Given this list of marker genes EHD1, MYOG (NCBI Gene Id 4656), MIR515-1, ADGRB1, RAPGEF3, TMEM182, GCM1, CXCL9, NFATC2, TREM2, MAPK14, MYOD1, EHD2, SCGB3A1, CD53, RIPOR2, GDF15, TNFSF14, IL4R, CAPN2, DCSTAMP, CCL8, CAMK1 (NCBI Gene Id 8536), CXCL10, CFLAR, PLEKHO1, FLOT1, OCSTAMP, ADAM9, TYROBP, here is a description of the gene set: studied in species Homo sapiens Any process that modulates the frequency, rate or extent of the formation of a syncytium, a mass of cytoplasm containing several nuclei enclosed within a single plasma membrane, by the fusion of the plasma membranes of two or more individual cells. Human Gene Set: GOBP_REGULATION_OF_SYNCYTIUM_FORMATION_BY_PLASMA_MEMBRANE_FUSION